The following is a description of a gene set: Human Gene Set: GOCC_CATSPER_COMPLEX studied in species Homo sapiens A sperm-specific voltage-gated calcium channel that controls the intracellular calcium ion concentration and, thereby, the swimming behavior of sperm. Consists of a heteromeric tetramer surrounding a calcium ion- selective pore. May also contain additional auxiliary subunits., and this is the list of marker genes: EFCAB9, CATSPER4, TMEM262, CATSPERD, TMEM249, HSPA2, CATSPERE, CATSPERZ, CATSPERB, CATSPER2, CATSPER3, CATSPERG, C2CD6, CATSPER1